Given this list of marker genes Npepps, Xpnpep2, Rnpepl1, Lta4h, Rnpep, Xpnpep3 (NCBI Gene Id 321003), Npepl1, Lap3, Metap2, Xpnpep1, Trhde (TRH-degrading enzyme), Mmp16, Enpep, Lnpep, Pepd, Mmp14, Metap1, Anpep, Erap1, Aopep, Metap1d, here is a description of the gene set: species: Mus musculus Catalysis of the hydrolysis of a single N-terminal amino acid residue from a polypeptide chain by a mechanism in which water acts as a nucleophile, one or two metal ions hold the water molecule in place, and charged amino acid side chains are ligands for the metal ions. Mouse Gene Set: GOMF_METALLOAMINOPEPTIDASE_ACTIVITY